The following is a description of a gene set: Human Gene Set: GOCC_AXONAL_GROWTH_CONE The migrating motile tip of a growing nerve cell axon. species: Homo sapiens, and this is the list of marker genes: COBL, OLFM1, TRPV2, TAOK2, NRXN1, MAPK8IP1, C9orf72 (C9orf72, member of C9orf72-SMCR8 complex), NIN, TRAK2, TRAK1, SHTN1 (NCBI Gene Id 57698), KIF21A, FLRT3, MYO9A, EPHA4, GPM6A, PTCH1, FKBP4, KIF5C, CLASP2, RTN4R, HSP90AB1, HSP90AA1, L1CAM, BOC, SCN11A